The following is a description of a gene set: species: Homo sapiens Human Gene Set: HP_INCREASED_URINARY_NON_PROTEINOGENIC_AMINO_ACID_LEVEL Increased urinary non-proteinogenic amino acid level An increased level in the urine of an alpha-amino acid which is not a member of the group of 23 proteinogenic amino acids., and this is the list of marker genes: SLC3A1, GCLC, AGXT2, PHYKPL, CTH (NCBI Gene Id 63046), IBA57, MMACHC, SLC7A9, ALDH4A1, AASS, LETM1, SLC13A3, PAH, TNFRSF11B, SLC6A18, SLC7A7, SLC6A19, ALDH6A1, SLC25A15, PRDX1, DMGDH, PLOD2, ALDH5A1, ASPA, LMBRD1, SLC36A2, DHTKD1, GGT1, SLC6A20, PRODH, MOCS1, NFU1, TNFRSF11A